The following is a description of a gene set: Any process that modulates the frequency, rate or extent of cardiac muscle contraction by changing the calcium ion signals that trigger contraction. Mouse Gene Set: GOBP_REGULATION_OF_CARDIAC_MUSCLE_CONTRACTION_BY_CALCIUM_ION_SIGNALING studied in species Mus musculus, and this is the list of marker genes: Tnni3, Hdac4, Fkbp1b, Tmem38b, Ryr2, Dmd, Casq2, Slc9a1, Pln, Ank2, Cacna1c, Atp2a2, Tmem38a, Atp1b1, Slc8a1